Given this list of marker genes PPP3CC, PPP3CA, PPP3R1, ITPR1, PPP3R2, PPP3CB, here is a description of the gene set: Human Gene Set: GOCC_CALCINEURIN_COMPLEX A heterodimeric calcium ion and calmodulin dependent protein phosphatase composed of catalytic and regulatory subunits; the regulatory subunit is very similar in sequence to calmodulin. species: Homo sapiens